Given this list of marker genes Aicda, Apobec3, Apobec2, Cdadc1, Cda, Pycr3, Apobec1, here is a description of the gene set: studied in species Mus musculus Mouse Gene Set: GOMF_CYTIDINE_DEAMINASE_ACTIVITY Catalysis of the reaction: cytidine + H+ + H2O = uridine + NH4 and deoxycytidine + H+ + H2O = deoxyuridine + NH4+.